The following is a description of a gene set: Mouse Gene Set: GOBP_PROTEIN_HEXAMERIZATION The formation of a protein hexamer, a macromolecular structure consisting of six noncovalently associated identical or nonidentical subunits. studied in species Mus musculus, and this is the list of marker genes: Yme1l1, Ugdh, Mat2a, Lrrc8a, Spast, Lrrc8c, Twnk (NCBI Gene Id 94248), Lrrc8d, Letm1